Given this list of marker genes STARD7, CHST11, MYBL1, FAM216A, PYCR1, PACSIN2, CERS2, PCTP, STK39, SLC18A2, PPFIA3, ESRRA, LAMC3, ATIC, FAHD2A, S1PR5, SERTAD3, ST3GAL4, PMM1, E2F3, SPINK4, ANP32A, IL21R (interleukin 21 receptor), MAGEH1, ZHX3, MLF2, CYP4F2, CDCA8, PSMB1, EYA4, MMP2, GAS2L1, KAZN, AHSA1, GGCT, FARS2, FKBPL, RAD54L, ACSBG1, C3AR1, TK2, DCTPP1, KDM1A, ZNF177, BIRC7, STOML2, C1orf216, C2CD2L, RNF187, FRMD1, PUS1, CD33, MAPK14, APOO, SRPRB, STX8, SYMPK, RIOX1, LARS1, BLCAP, MTCH2, ARMC8, GGCX, SRF, MRPL35, SETD6, HSD17B4, H6PD, RXRG, RBM38, UBE4B, SEPTIN8, NFE2, TRAF4, GRK5, SLC25A22, FGF21, HIBCH, TIMM8B, ZNF106, SNRNP25, PKP4, CTPS2, MYCN, HDAC2, MTMR4, SECISBP2, CSTPP1, PINLYP, CPA3 (carboxypeptidase A3), MBL1P (mannose binding lectin 1, pseudogene), GPD1L, AP1S1, ALDH5A1, RHOT1, NOL9, IARS2, SYNE1, FHL3, GNB2, RPL26L1, FAM136A, KIF11, MAPKAPK3, CYB5B, JUP, PSTPIP2, CAMK2G, DSN1, PPP2R5D, DNAL4, BCL2L1, FNBP1, FBXO24, DEAF1, FBP1, HDDC2, SCAI, IKZF1, BICD2, PRMT1, DIABLO, IQSEC2, TIMP3, HMMR, ARNT2, ATP7A, TMEM39B, MCUR1, MRPL17, NHP2, NLE1, FGD1, TPX2, GGPS1, PRPH, DHCR24, ATP5MC3, PRPF19, MRPL24, TRAPPC2, MZT2B, SUCLG1, GFI1, CHMP1A, PIAS3, RFX5, PSMF1, DLST, ATP5MC1, POLR2E, TIMM13, EIF5A (eukaryotic translation initiation factor 5A), AGFG2, ZNF768, CCDC51, RSAD1, KIR2DS2, COA3, DDX19A, SCPEP1, ELK4, TKT, PRKAB1, BIRC5, IFT56, CBX4, SNX5, PRCC, TRIAP1, CDC42BPB, MCM7, EMILIN1, CARD9 (caspase recruitment domain family member 9), RAB11A, H2BC12, MTFR1, HAGH (NCBI Gene Id 3029), EIF2B1, VDAC3, SSBP3, ST3GAL5, TRAF3IP2, PTER, ASIC1, C2CD2, DCP2, SYNJ2BP, CAMK2N1, STRADA, CIAO1, CCNB2, RFX7, SLBP (stem-loop histone mRNA binding protein), ITPA, UQCRFS1, CENPA (NCBI Gene Id 1058), SNHG20, LMO2, KIR2DL3, here is a description of the gene set: from publication Choi JH, Banks AS, Estall JL, Kajimura S, Boström P, Laznik D, Ruas JL, Chalmers MJ, Kamenecka TM, Blüher M, Griffin PR, Spiegelman BM (PMID 20651683) In order to identify the molecular mechanisms of PPARgamma phosphorylation at Set273, we generated cell-lines of PPARgamma KO MEFs expressing wtPPARgamma or S273APPARgamma. In addition, because our data showed that PPARgamma ligand drugs such as rosiglitazone and MRL24 blocked this phopshorylation, we treated cells with these drugs, then prepared RNA samples to look at the gene profiling. Human Gene Set: GSE22033_UNTREATED_VS_MRL24_TREATED_MEF_UP species: Homo sapiens Genes up-regulated in mouse embryonic fibroblasts (MEF): untreated versus MRL24.